Given this list of marker genes LINC01836, SGCG, NPY5R, MYH11, COL3A1, PRELP, FHL5, MSC-AS1, SRPX2, C1QTNF7, ISLR, TRPA1, TMEM119, THPO, PTCH2, TAGLN, C6, DCDC2C, GLI2, TCF21, PODN, CYP1B1, PGM5P4, CYP4X1, DMKN, DKK2, PDGFRA, LINC02507, KDELR3, SULF1, RXFP2, LINC01031, MYOCD, MGP, FMOD, IGFBP3, LRRC17, ABCC9, ACTG2, ZFPM2-AS1, RXFP1, OSR1 (NCBI Gene Id 4955), PDE1A, WT1, MIR1245A, ENSG00000225649, PDGFRL, ADAMTS9-AS1, IL6, LINC02126 (NCBI Gene Id 101927650), DIO3, DIRC1, EBF3, EDNRA, PI15 (NCBI Gene Id 51050), LINC02873, COL1A1, ASPN, LINC02082, WNT2, SULT1E1, PCDH18, CDH11, LINC02653, PI16, RPL13AP11, GLP2R, OLFML1, POM121L9P, WT1-AS (NCBI Gene Id 53590), C7, GJB2, FAP, RSPO2, NGF-AS1, LINC02026, ABCA6, GDNF-AS1 (NCBI Gene Id 101929745), LINC03041, COL6A3, CCDC102B, DCN, SCARA5 (NCBI Gene Id 286133), PAMR1, CNTN4-AS2, MSC, MXRA5, PRICKLE1, BICC1, GATA4, DNAJC22, CARMN, FGF7, ENSG00000223786, PCOLCE, LRRC71, COL12A1, FMO1, HHIP, VIPR2, ACTA2, POSTN, BPI, ENSG00000272243, RSPO3, FNDC1 (fibronectin type III domain containing 1), PRRX1, ITGBL1, CCDC80, MEOX2, ABI3BP, LUM, COLEC11, C1R, ITGA11, ENSG00000248576, FOXS1, PTH1R, METTL24, IGFN1, LINC02643, OGN, AARD (alanine and arginine rich domain containing protein), LINC00702, ZNF385D, TBX18, FREM1, NPAS1 (neuronal PAS domain protein 1), AGTR2, ADAMTS14, IGFBP6, ADAMTSL3, ADAMTS15, GAS2, TWIST2, SFRP2, ADH1B, PCOLCE-AS1, LAMC3, NGF, THBS2, PLA2G5, REM1, EMX2OS, CCN4, BMP4, LOX, CYP4Z1, CLDN11, TDO2, CBLN4, ANO1, CD248, CHRDL1, TRPC4, ADRA1D, here is a description of the gene set: Marker genes curated from the annotated cluster as represented in the Descartes Human Gene Expression During Development database. from publication Cao J, O'Day DR, Pliner HA, Kingsley PD, Deng M, Daza RM, Zager MA, Aldinger KA, Blecher-Gonen R, Zhang F, Spielmann M, Palis J, Doherty D, Steemers FJ, Glass IA, Trapnell C, Shendure J (PMID 33184181) The gene expression program underlying the specification of human cell types is of fundamental interest. The study authors generated human cell atlases of gene expression and chromatin accessibility in fetal tissues. For gene expression, the study authors applied three-level combinatorial indexing to >110 samples representing 15 organs, ultimately profiling ~4 million single cells. The study authors leveraged the literature and other atlases to identify and annotate hundreds of cell types and subtypes, both within and across tissues. Our analyses focused on organ-specific specializations of broadly distributed cell types (such as blood, endothelial, and epithelial), sites of fetal erythropoiesis (which notably included the adrenal gland), and integration with mouse developmental atlases (such as conserved specification of blood cells). These data represent a rich resource for the exploration of in vivo human gene expression in diverse tissues and cell types. Human Gene Set: DESCARTES_FETAL_ADRENAL_STROMAL_CELLS species: Homo sapiens